Given this list of marker genes TTC6, TMEM181 (NCBI Gene Id 57583), NCK1, MKRN2 (makorin ring finger protein 2), PIP4P2, SLC12A1, SURF2, KMT5B, WDR74, USP36, FBXL14, ANAPC16, DCBLD2, RAD9A, SLIRP, MTHFD2L, CYP2E1, COX18, ZFAND5, DIS3, TAF1D, CD164, KLF2P3, NOC3L, SNAP25-AS1, COX6B2, DNAJA2, CCDC124, PARK7, ABT1, TDG, MAT2A, CAHM (colon adenocarcinoma hypermethylated), KLHDC2, GTF3C3, EZR, PHF3, EPHB4, METTL15 (NCBI Gene Id 196074), UGDH, SMIM26, C2orf72, RN7SL688P, ZNF778-DT, C11orf65, VRK3, PIGO-AS1, PSMD3 (proteasome 26S subunit, non-ATPase 3), LINC03100, CD300LG, ENKD1, WASHC4, ERRFI1, HMGB1, MCM6, RN7SKP114, KPNA5, ANXA5, EIF4G1, TRAF3IP1, RESP18, AOPEP, SNORA16A, SUFU, ORC3, DNAJC28, CLIC1, TMEM220, NAGK, SPTSSA, SMAGP, NR1D1, CUL4A, GTF2A2, UBXN2A, ABHD13, ZNF529-AS1, TTYH1, CDIP1, RAB13, NCL, PI4KA, TTI1, MIS12, BBS2, CCT6A, IL10RB-DT, NDEL1, MED17, MTMR2, RIDA (reactive intermediate imine deaminase A homolog), TUT4, NT5DC2, USP27X, TACO1, TARS2, KEAP1, MYOSLID-AS1, ZNF232, ING5, EXOC3L1, NBEAL1, NAE1, CZIB, RTTN, GARS1-DT, C16orf86, TGFBR3, ZNF549, CCNL1, GPSM2, TRMU, ACOX3, NAA20, SCAF11, RTEL1, HEY1, LUC7L2, GRPEL1, ELMOD3, PTMA, COPZ1, P2RY2, XKR9, HLTF (helicase like transcription factor), RPL36AL, BNIP2, FAIM2, ACSL3, IRAG1-AS1, QSER1, HSPH1, SLC25A10, ACAP2, MARK4, AP3S1, ZSCAN16-AS1, YTHDF2, FAM20A, HIF1AN, CNNM4, C7orf57, PARN, CCSAP, PIDD1, XRCC5, BPHL, TMEM220-AS1, TSEN54, TMEM50B, GAS8, KRI1, RPL6, KPNA2 (karyopherin subunit alpha 2), HSDL2-AS1, FAM83C-AS1, H3-3B, CISH, MEMO1, GOSR1, ACTR5, EBPL, ZCCHC2, C21orf91, LMBR1, MED15P9, TMPRSS3, LACTB2, KIRREL3, GSTCD, INSM1, MAGEF1, NPPB, NIPA1, HNRNPD-DT, ENSG00000267882, TVP23C, KIF16B, CERNA3, NUF2, KDM2A, YPEL1, FANCI, URGCP, CKLF, AGO3, CLN6, TOR3A, H6PD (hexose-6-phosphate dehydrogenase/glucose 1-dehydrogenase), AHDC1, FUS, WDR11, POMGNT2, DONSON, ENSG00000279561, GPNMB, ELOVL1, KCTD21-AS1, H2BC7, NBN, KCNC3, GALE, PYCR1, ST7, MAGOH-DT, LINC02256, PRIM2, CCM2L, NOL10, CTXN2-AS1, ZNF782, UAP1, NUDCD2, TLCD3B, EEF1AKMT2, BBOF1, CILK1, GDE1, MINK1, DBP, POR, SPTBN4, ELP4, EP300-AS1, RGS5, GPRIN1, ZNF23, OXSR1, RPP40, C11orf68, CALM1, AURKAIP1, GTF3A, VWC2L, MAP2K2, ATIC, FBXL17, GSDMD, HDGF, AHSA2P, DPH7, RFC2, XRCC3, GPR158 (G protein-coupled receptor 158), VMAC, ANKRD40, MIR9-3HG, RPL13A, BLM, MIR1302-3, BABAM1, FBXO34, H4C3, RNVU1-19, NUB1, CCZ1B, PRKDC, MTR, ARHGEF37, MFSD11, GPR78, FASN, SNX1, NET1, SPTBN1, TXLNG, CREB1, USPL1, RPN2, USH1G, ZNF451, NMNAT1, GTPBP10 (NCBI Gene Id 85865), BMPR2, WDR31 (WD repeat domain 31), TMEM117, PTPRS, RPRD1B, FGD6, COPS7B, EPB41L5, HPD, PPM1N (NCBI Gene Id 147699), USP19, PSPH, TALDO1, UBE2C, MT1F, RNU4-1, NDUFAF1, RNU7-27P, SOCS4, ZFPL1, TRIM26, UQCC6, RNF114, RNF130, ACTN4, HES1, CYB5R4, LIMS1, POP1, LINC02777, MCU, GIT1, TSPAN14, MSRA, SRA1, YKT6, MMAB, MKKS, GPX2, IQCN, TUBB4B, LAMP1, ORC2, RNU4-2, SLC7A5, TOMM22, ABHD5 (NCBI Gene Id 51099), GLI4, RXFP3, DPH6-DT, RCOR3, ZSCAN12, EIF1AD, PARAIL, RAD51C, ISCA1, HDAC2-AS2, NELFB, CEACAM16-AS1, ANAPC7, CTXN2, PDE4C, SMARCAD1 (SWI/SNF-related, matrix-associated actin-dependent regulator of chromatin, subfamily a, containing DEAD/H box 1), RNVU1-14, ST7-OT4, EBAG9, RRAGAP1-AS1, CRYBB2P1, LACTB2-AS1, APOC2 (apolipoprotein C2), ASAH2B, ALDOA, STYXL1, TUBB2A, NUP153, MLNR, PLGRKT, MOGAT1, NT5DC1, EIF3H, SLC25A12, MSTO1, ASH2L, BMS1, VARS1 (NCBI Gene Id 7407), DEDD, HAX1, IST1, RASSF3, RBL1, PCID2, GCC2-AS1, HEXD (hexosaminidase D), SAFB, SEC24B, TASOR2, AKAP10, IL9, HDDC3, CBLL1, TBKBP1, MGAT4A, NCK1-DT (NCK1 divergent transcript), KCNK12, SPAG4, TUT7, ZFAND2A, SPPL2B, IFT56, ZNF774 (zinc finger protein 774), KCNJ11, SLC8A2, SNX21, PAQR4, PHLDA1, ASCC1, SLC16A5, THSD4, GRIN1 (NCBI Gene Id 2902), AEN, ZDHHC6, H2AC17, FNBP1P1, GUCY1A2, BCL7C, SLC18B1, LRRC59, BANF1, CACNG6 (NCBI Gene Id 59285), SMARCAD1-DT (NCBI Gene Id 101929210), UBE2K, NRBP1, ENTPD4-DT, IL4I1, H2AC7, PLEKHM3, TMBIM6, MTF2, METTL5, H4C12, GLTC1, VPS39, ADAP2 (NCBI Gene Id 55803), SLC9A3-OT1, MRPL3, ADAT2 (NCBI Gene Id 134637), RNF166, MAP4K1, ACYP2, USE1, AXIN2, CLCN7, PGGT1B, MPC1, COPS9, RNH1, BRF2, LINC01976, COL9A2, RN7SL1, PPP4R2, ASTE1, BSX, LIME1, HPS4, SNRNP70, RCN1, IRF1, PTGES2, GPR152, WDR43, CNN3, DLGAP4, RPL37, SLC1A5, MPV17, FANCC, ALKBH4, LSM7, ZNF669, NSFL1C, CRELD1, POLR2J, HIRA, CTCF-DT, IPO11, GSTZ1, MCPH1, PRMT5, NME1, MRPL45P2, UBE2V1, CAMKMT, THADA, ITGA3, PBX3, C14orf93, ZNF337-AS1 (NCBI Gene Id 102725221), EIF1, ANKRD12, SNRPC, COQ10A, SNORD60, UBAP2, TRAK2, NUP107-DT, SCG3, EXOSC3, MGME1, GTF3C5, SYP, LZIC, MAPK6-DT, GATB, RWDD3-DT, HNRNPD, SYN1, SLC38A2, WFDC3, FASTKD3, DUS1L, MIR4470, CDAN1, ACSS2 (acyl-CoA synthetase short chain family member 2), SHC1, MRPL12 (mitochondrial ribosomal protein L12), TEKT3, HHATL, EVI5, SERPINB9, LYRM2, ODC1-DT (NCBI Gene Id 102723993), EEA1, LRWD1, EIF2D, TIGD1, DAZAP2, AFG2A, CHRNB2, MAPKAPK3, SLC7A5P2, CSAD, RSAD1, PRLHR (prolactin releasing hormone receptor), GADD45GIP1, CTNNB1, AFG3L2, ENSG00000265055, PPIL2, MTA3, JPX, INTS12, PRDM10-DT, RNA5SP60, ZBTB8B, ASPH, ASMTL, JRK, ERRFI1-DT, FUT6, C16orf87, SNHG17, TARS1, SLC25A28-DT, NKAIN1, STARD7, STAM2, CBX4, PSMF1, FYTTD1, FANCA, C17orf75, HERC3, GADD45A, POLR2C, TOP3B, CLOCK, VGF, PRCP, KIAA1755, H2BC17, PXN-AS1, ZNF583 (zinc finger protein 583), C5orf63, SRCIN1, CLPB, NUP214, MPST, CRY2, ALG14, ANO7, ADNP, TCF25, BTBD9, EFHD2, LGALSL (NCBI Gene Id 29094), PLXNC1, TTC12, EFCAB13, DCP1B, UGDH-AS1, EHHADH, LEPR, GOLGA8B, SART1, WHAMMP3, PKMYT1, SHCBP1, ZNF740, UFM1P3, CCDC88A, CYP4V2, MTMR9, EZH2, NDUFS8, CFL2, RETSAT, BAG6, SNORD49A (small nucleolar RNA, C/D box 49A), RPS20, CAMK2B, MAILR, NSG2, MST1P2, ZNF773, HAUS7, NUDT1, STK10, PARP16, P2RX6, POLR2J4, UPF1, PIK3R1, MST1, HES4, EIF3K (eukaryotic translation initiation factor 3 subunit K), COX16, ISG15, CARINH, SLC39A3, SEZ6, ERC2, NMBR, DGAT2, FOS, CES2, DHX8, ADSS1, DEXI, ZNF799, RMND5B, UFC1, KCNS2, EXOSC9, ID2-AS1, SMG1, FAM217B, HMGB1P8, EIF3B, MEX3D, FUT3, E2F1, THOC3, ABCB10, CENPN-AS1, TMEM107, AARS2, CDC42EP1, TNIP2, MRPL44, CROCCP2, TOMM34, COBLL1, PNRC1, SP3, RPS7, THBS1, SNAP29, TRNT1, MAP4K3, IKZF3, NPIPB2, CRTC3-AS1, SNX4, UNC119, GABARAP, USP10, RPLP0, PGBD5, MRPS15, ZFYVE21, NAA50, TUBGCP3, NPC2, HAUS4, LINC01719, ATMIN, YIF1A, GPR6, HRAS, TMEM106B, SLC34A1 (solute carrier family 34 member 1, NCBI Gene Id 8561), ALYREF, LHX3, COG7, NAPA, PREPL, DENND6B (NCBI Gene Id 414918), PTDSS1, RBM28 (RNA binding motif protein 28), VPS13C-DT, RNF123, FAR2P3, PEDS1, FBXO38, CYB5RL, SAMD4B, SEC14L1, RARS2, CHAMP1, GDPD1, STX4, HS3ST2, PNN, SNORD54 (small nucleolar RNA, C/D box 54), VPS39-DT, EFHD2-AS1, CCDC25, DGUOK, OGFOD3, ARL5A, UAP1-DT, HS3ST3B1, CKS1B, MIR5588, SNHG29, FAM227B, IGF2R, NEPRO, DDX19A-DT (DDX19A divergent transcript), ENSG00000229797, NORAD, HOXA4, RBP4, TRAF4, SRSF11, VAC14, RERE, PELI2, LINC01607, UNC13A, SCRIB, ALKBH1, ATG12, MMP15, DGAT2-DT, ARF5, NEAT1, ENTPD5, STX18-AS1, CAMTA1-DT, MARK3, MTERF3, ZNF786, JAGN1, IMMP1L, TOMM22-DT, RPL39, MGAT5B (NCBI Gene Id 283995), DUS2, POGK, ZNF24, TENT5B, WDR11-DT, ZNF592, DRAP1, CALCOCO1, SPOP, BICDL1, SLBP, APBB2, CTNNAL1, LTO1, LIPT2, UBE4A, LIN28B-AS1, UBE2D4, NOXA1, LRCH3, MVK, THAP4, RAB32, YARS1, TIMM44, ACOT7, MAP3K10, AKIRIN1, LRP6, VDAC3, MRPL40, ERN1, SREBF2 (NCBI Gene Id 6721), CUL7, PLAC8, SRRD, R3HDM2 (R3H domain containing 2), SNHG32, PDK2, SLC2A4RG, NSL1, C18orf21, TMEM241, RNF141, PGS1, MAZ, BFAR, GRM1, CASD1, LINC01664 (long intergenic non-protein coding RNA 1664), TUBGCP5, TRAM1, RUVBL2, AK3P5, STK35, GABBR1, NR4A2, SEMA3F, OGDHL, HSD17B11, TMEM14C (transmembrane protein 14C), KCNG3, SLC16A3, CKLF-CMTM1, NEK11, EIF6, MGA, TGIF1, SMG1P1, CCT8, ZNF212, TATDN3, AJUBA-DT, PPP1R9A, UBE2D3, ATF1, HERC2P2, STMN3, OPRM1, EXT2, PIGO, ATP1A1-AS1 (NCBI Gene Id 84852), ANAPC10, DNM1, MAPK8, LEPROT, NDUFV2-AS1, E2F5-DT, BRAT1, CATSPER2P1, DNAJC7, BPTF, DPH6 (diphthamine biosynthesis 6), LYPLA2, ZNF30-AS1, RNU6-1276P, CEBPG, TVP23C-CDRT4, ACAD9, PMPCB, NGRN, MARCHF4, CLPP, ZFAS1, ZNFX1, APOC4-APOC2, MARCHF8, LIG4, MTIF3, FAM21EP, UTP11, PPP1R12C, PNKP, BCAR3, GLIS3, SMAP2, SEC1P, SLC25A28, SLC44A1, CDKN2AIP, KCTD13-DT, ATF5, CIAO2B, MTRR, MIR320A (NCBI Gene Id 407037), DHDDS, AGPS, PIBF1 (progesterone immunomodulatory binding factor 1), XPOTP1, NUP54, CPLX2, DNTTIP1, DHRS4L2, EXD3, KCNQ1OT1, TMEM272, DENND2B, SMIM13, RIC8A, LMCD1, FAM222A-AS1, AJUBA, N4BP2, CCDC183, ENSG00000248367, HNMT, AKR1B1, FOXA1, VRK2 (NCBI Gene Id 7444), UROS, ERMAP, TIRAP, SCAMP5, ARHGAP11A, ZNF821, TMEM14A, CDR2, COQ8A, FOXN3, RASSF3-DT, PEDS1-UBE2V1, AP1B1, TPST1, MARCHF7, MDH2, GINS2, MEAF6, PARVA, GRIA2, ATXN2L, COMMD4, ALKBH2, TMEM109-DT (TMEM109 divergent transcript), NR3C1, METAP1D, ZNF569, ENSG00000213963, UTRN, FBXO38-DT, HMGA1, ACP2, COMMD1, ZBTB40 (NCBI Gene Id 9923), USB1, SOCS1, KRCC1, PATZ1, CDC16, ZNF441, AGK, MAP4K3-DT, VPS13C, DHCR24-DT, DNAJB14 (DnaJ heat shock protein family (Hsp40) member B14), DSTYK, RBBP6, RITA1, LTV1, DNER, NCEH1, HSD17B12, OPRL1 (opioid related nociceptin receptor 1), SLC22A23, ID2, MSH5, PFKFB3, PIGC, ANAPC11, ANGEL1, HCG9, FMNL3, CDHR2, ZKSCAN8P1, RTEL1-TNFRSF6B, RBM18 (NCBI Gene Id 92400), FASTK, SNRNP27, HTR1A, PHLDA1-DT, SREK1, SNX5, EP300, APOF, POMT2, GOLIM4, PRIMPOL, ADD1, LINC01703, BTG2, MIS18BP1, PIEZO1, OSTF1, MAML3, APOA2, TTC12-DT, LYZ, IL5RA, E2F3, MRPS25, NOC2L, SNHG6, POLR1F, ZNF781, SNORD48, TENT2, TAF12, PNPT1, MARCHF5, TUBA1C, RNF19B, MAN1C1, PPM1G, SLC24A1, HMGCS1, PELATON, ALDH2, NDUFAF8, LEMD3, SLC47A1 (solute carrier family 47 member 1), ZNF30 (zinc finger protein 30), PCLAF, PGRMC2, ASXL1, FIP1L1, TFDP1 (NCBI Gene Id 7027), ARID1A, SLC25A34, BCKDK, HLCS, CTCF, MAPKBP1, PRDX1, SAR1B, GATAD2A, CPSF1, TECPR1, AP5Z1, SURF1, TM2D1, MFF-DT, LNPEP, ADPRS, XPC-AS1, ATP8B3, MTRF1L, ACSL6, ALG8, FAIM, FRG1HP, ORMDL1, WDR12, ENTPD1-AS1, B4GALT3, SENP5, CTSB, ZBTB45, RNF32, ABCB6, DDX39A, RNVU1-28, ZFP30, KCTD13, COX7C, PLEKHO2, EEF1A1, HUS1, CETN3, LGALSL-DT, LINC00680, TTC22, ST7-AS1, PBX3-DT, MON2, GNPAT, RPL13P5, ATXN7, PDE6D, KCNB1, NPDC1, NDFIP2, HDAC2, STOM, PGF, RPH3A, ZNF767P, PNMT, IL10RB (interleukin 10 receptor subunit beta), SPIDR, CEBPB-AS1, ZNF529, PYURF, PFKFB3-AS1, MTERF4, H1-4 (H1.4 linker histone, cluster member), CTU2, ENSG00000260136, KANSL1, PGBD1, SAFB2, CPEB3, SLC25A25, GPATCH11, VSX1, BAIAP2-DT, ZNF398, NMD3, TVP23B, SLC27A5 (NCBI Gene Id 22942), RASIP1, FBXO34-AS1, RPS9, DRG2, ZFAND2A-DT, ZNF391, MAPK6, NUP107, SRRM3, ENSG00000277020, CEP295 (NCBI Gene Id 85459), PTPN11, RMRP, POLD3, TRIP4, TXNL1, PPP1R3C, KBTBD4, RGMB, SSR4P1, STAT3 (signal transducer and activator of transcription 3), WDHD1, MLXIPL, TARS1-DT, FABP1, MRPS28, TMEM242-DT, AMER3, ZFY, NPLOC4, LINC03051, FLJ38576, KCNH6, TRAPPC9, CCDC57, VPS72, NDUFAB1, AZIN1, CDCA5, RHEB, FAAP20, SMARCE1, LINC01124, PAFAH2, NDFIP2-AS1, SEC14L5, PLSCR4 (NCBI Gene Id 57088), AGBL5, HDAC5, LINC02851, SMG1-DT, SNIP1, PDCD2L, SPSB1, ROR1, MSRA-DT, COPS6, CAAP1, OIP5-AS1, ARHGAP11A-DT, PA2G4, VTI1A, ABCF1, TRIM67, ASNSD1, AFDN-DT, MIR7-3HG, NUP62, ABCE1, VPS28, SESN2, WDR37, IFFO2, STAT1, RRP15, NR1H3, E2F6, HYLS1 (HYLS1 centriolar and ciliogenesis associated), BTG2-DT, NME6, MRM2, GCFC2, HHATL-AS1, SLC22A31, PRUNE2, FOXQ1, METTL22, RANBP3-DT, GARS1, RAP1B, TMC8, MAGOH, TFDP2, BARHL1, RNF227, ADGRB3, TM7SF2, GPN1, GSR, NSMCE4A, STX18, PPFIA3, STMP1, NDUFA11, GEMIN7, RPS29, NME1-NME2, ZNF805, H3C12, FAM53C, HAPSTR1, MNAT1, AP3B2, TSSC4, NDUFS3, NUP58, MIR7-3, SNHG12 (small nucleolar RNA host gene 12), TNFAIP8L1, NOP14, DNAJC11, AFMID, TMEM39A, RBM12B, CIZ1 (CDKN1A interacting zinc finger protein 1), SEZ6L2 (seizure related 6 homolog like 2), SGK3, DYRK4, ATP5ME, CAMTA1, STK25, HLF, MRPL58, NOM1, LZTR1, STAT4-AS1, PARD6B, TPD52L2, GTPBP4, INTS14, ARRB2, GEMIN8P4, TPH2, MFAP3L, TK1, ZNF473, SUGT1P1, ALCAM (NCBI Gene Id 214), TMEM222 (NCBI Gene Id 84065), USP40, ZBTB38, TCEA1, PPP6R1, NFATC3, GNAI2 (G protein subunit alpha i2), POTEF, LINC00511, DIDO1, ABCC2, PLA2G12A, NFE2L2, SLC25A6, GLRA1, GLS2, ITGB3BP, HMMR, FGFR4, CZIB-DT, TPCN2, LINC01881, ELAVL1, CDC25C, SP5, CDH23 (cadherin related 23), TMED7-TICAM2 (TMED7-TICAM2 readthrough), MIR153-1, TOR1A, CASKIN2, SVBP, GID8, FAM162A, NXF1 (nuclear RNA export factor 1), ID3, EMC1, PPIA, DHCR24, TMEM231, TK2, DENND11, CEBPZ, SLC9A1, SEC63, GOLGA8A, GRM2, MRPL37, KHSRP (NCBI Gene Id 8570), SNTG1, ISLR2 (NCBI Gene Id 57611), KATNA1, LNX2, TIPIN, SMG1P3, NPM3, ENSG00000232995, ABCA3, KRR1, ADSL, PLCH1, CHTOP, AFDN, RESF1, WDR6, IFT88, GDAP1, ILKAP (NCBI Gene Id 9345), UBE2Q1, ANKRD52, LINC00485, ARMC9, KIAA1958, ZC3HC1, ZNF564 (zinc finger protein 564), TTC19, MOSMO, ACAT1 (acetyl-CoA acetyltransferase 1), SSR3, RPL12P41 (ribosomal protein L12 pseudogene 41), TEPSIN, TMEM179 (transmembrane protein 179), LINC01586, ENSG00000267248, DNAH14, HACD1, THAP1, MAPK9, POLR3D, SYT7, SCRT1, ZSWIM7, FRG1BP, EBLN3P (endogenous Bornavirus like nucleoprotein 3, pseudogene), MRRF, EDC4 (enhancer of mRNA decapping 4), MSH3, ACTB, RANBP3, LINC01521, USP4, CCNC, RIF1, WASHC2A (WASH complex subunit 2A), MESD, B3GNT3, IDI1, GYS1, MASP2 (NCBI Gene Id 10747), DDX19A, ENSG00000255647, MTA2, VTA1, CEP19, TBL3, CT62, SFSWAP, EXOSC4, POLR1D, ROCK2, DHFR (NCBI Gene Id 203373), MRPS31P5, DERL2, TBL1X, MCRIP2, RN7SL521P, EIF4E2, ENSG00000257184, PTPRN, MARCKSL1P2 (NCBI Gene Id 100913182), SOCS7, RPL31, ACTL6B, RAP2B, MAP2, FAM118B (family with sequence similarity 118 member B), ZNF319, CCDC121, ANKRD34C-AS1 (ANKRD34C antisense RNA 1), PSTK, NECAB3, HEBP2, DPY19L2P2, NEPRO-AS1, BRI3, LHFPL5, ANO10, IQGAP2, TBX6, NPRL3, NR4A1 (NCBI Gene Id 93352), LINC00494, MT1E, PTBP3, MICU2, SCGN, RAD23A, MAPK8IP2, EPB41L4B, ITPRID2-DT, NXPE3, NMRK1, TLCD1, PIGK, VTI1B, LMF1, PSMB4, WDSUB1, EDF1, WDR7, OAT, TM9SF1, RNF14, C1orf131, PPARG, DIMT1, GLDC, MSL2, CSNK1A1, NABP2, RANBP6, CASP3, PTP4A2, ZNF570, ENSG00000227355, APLP2, PPP1R3D, ARHGAP42 (Rho GTPase activating protein 42), AKAIN1, CD274, RWDD3, TMEM268, CDC42SE1, SLC35E2B, S100PBP, MRPL39, ZNF778, VEZT, TEX14, NDUFAF7, PNPLA2, CDKN2AIPNL, OTOP2 (otopetrin 2), PIGX, ZNF609 (zinc finger protein 609), DTWD1, TRIM37, CCDC144BP, RARA, IFT74, TBC1D19, EEFSEC, TAF11, MCM4, GRK4, SNRPB2, DPY19L4, MAPK11, SNORD118, ALG1, LTBP2 (NCBI Gene Id 83981), DUSP7, MFF, PGM1, ENSG00000275765, OSBP2, LMCD1-AS1, PYGB, CXXC5 (CXXC finger protein 5), MLLT1, RDH14 (retinol dehydrogenase 14), BCAT2, RNF41, BCCIP, RGS19, PECR, G3BP1, RIPK2, PKDCC, BAIAP2, MIDN, GLIS2-AS1, RPUSD4, EFCAB13-DT, KLF11, TAF1B, DNLZ, ABCA17P, R3HDM2-DT, RBPJ, ITPRIPL1, MRPL35, TMEM169, ZNF517 (NCBI Gene Id 340385), IMPA1, SLC9A3-AS1, C15orf40, VAMP1, DOLPP1, CDC27, SAR1A, C19orf73, TYMS, EXOSC6 (exosome component 6), ODC1, ITPRID2, ZNF707, LUZP1, LINC01970, ZNF232-AS1, PSCA, CHD6, CALB1, RBM12B-DT, RNVU1-31, TMEM87B (NCBI Gene Id 84910), SOS1, SLC38A1, PCSK1, TJP1, NUDT6, STRADB, ASPHD1, HTR5A (NCBI Gene Id 3361), RN7SL832P, UNC80, RPL14, C1QBP, TAF12-DT, MIX23, NRP2, HRH3, TAF15, PPM1H, STEAP1B, RBFA, LLGL2, MAP4K4, ENC1, DDX49, PSEN1, STAU2, TNNC2, NUBP1 (NUBP iron-sulfur cluster assembly factor 1, cytosolic), LRRC23, MSH5-SAPCD1, OSBPL3 (oxysterol binding protein like 3), FHAD1, EFHD1 (EF-hand domain family member D1), CHROMR, TEFM, PEX3, ENTPD4, SNX29, STAU1, KDM3A, IFT74-AS1, PPP1CB, ATP6V1A, OSCP1, TMED7, ECHDC1, SUMF1, ZNF326, PMS1, MYO1A, TTC4, CGRRF1, BCAT1, NCOA3, SRSF2, KCNC1, SLX9, MAPK13, TUT1, VCPKMT, CISD1, PPP5C, GSX1, QKI, DAG1, LINC01547, ADAM22, LUC7L, ANXA4, LHFPL4, RUBCN, FANCG, LARP1B, SSR2 (NCBI Gene Id 6746), WDR70, TRAF7, EFR3A, RRBP1, FSTL5, NCOA5, AGK-DT, DNAJA2-DT, EIF2B3, NEUROD4, MRTO4, ZER1, ATG4B, PRSS27, DTD1 (NCBI Gene Id 92675), TSPAN10, MROH8, COPE, FEZ2, SMARCD2, SVOP, RNVU1-6, MGAT2, WWC2-AS2, FRG1CP, ISCA2, JADE1, CERS6, SNORD12C, BET1L, CFAP410, COIL, CDH24, SHQ1, NDE1, SDAD1, PRDX4, RCE1, TOR4A, RMDN2, PRMT5-DT, WHAMMP2, SNORA14B, UBE2D2, SRARP, TP53INP2, ZYG11A, TMEM242, PEX5L, SNHG11, MED23, ENPP3, PDIA3, SNORD49B, DDX31, GTF2IP4, GTF3C4, SLC39A13, ROCK1P1, ZNF425, LINC00674, FAM131A, here is a description of the gene set: from publication Yevshin I, Sharipov R, Kolmykov S, Kondrakhin Y, Kolpakov F (PMID 30445619) studied in species Homo sapiens Human Gene Set: ZBED5_TARGET_GENES Genes containing one or more binding sites for (ZBED5) in their promoter regions (TSS -1000,+100 bp) as identified by GTRD version 20.06 ChIP-seq harmonization.